Given this list of marker genes FLT1, GSTM3, GCLC, THOC2, CLCA4, EDNRA, SLC16A2, SLC9A3, CEACAM3, STX1A, SLC6A14, CFTR, STOX1, SLC2A3, SLC26A9, THRA, CEACAM6, HMOX1, SLC11A1 (solute carrier family 11 member 1), SERPINA1, ANKH, HTT, DCTN4, TNFRSF11B, KCNJ11, SLC25A13, TGFB1, CORIN (corin, serine peptidase), HFE, KCNN4, MIF, here is a description of the gene set: Human Gene Set: HP_ABNORMALITY_OF_BODY_MASS_INDEX Anomaly in the weight-to-height squared ratio, calculated by dividing the individual's weight in kilograms by the square of the individual's height in meters and used as an indicator of obesity and underweight compared to averages. Abnormality of body mass index species: Homo sapiens